Given this list of marker genes MEG3, PTCH1, CCN2, AIFM1, EFL1, SUFU, DDR2 (discoidin domain receptor tyrosine kinase 2), COL2A1, CFAP410, SBDS, COL11A1, ADA, RTL1, PTCH2 (patched 2), SRP54, DLK1, SLC35D1, INPPL1 (inositol polyphosphate phosphatase like 1), DNAJC21, COL10A1, here is a description of the gene set: Human Gene Set: HP_ANTERIOR_RIB_CUPPING Wide, concave anterior rib end. studied in species Homo sapiens Anterior rib cupping